The following is a description of a gene set: species: Homo sapiens Human Gene Set: GOBP_REGULATION_OF_PEPTIDASE_ACTIVITY Any process that modulates the frequency, rate or extent of peptidase activity, the hydrolysis of peptide bonds within proteins., and this is the list of marker genes: SERPINB9, PSENEN, CR1, CRB2, FETUB, PRSS22, SEMG2, SEMG1, ATP13A2, SERPINB1, EPPIN (NCBI Gene Id 57155), RCN3, TIMP2, TANK, TIMP1, SPOCK3, GAPDH, SVBP (small vasohibin binding protein, NCBI Gene Id 374969), PRELID1, MBP, UBXN1, SERPINB13, ECM1 (NCBI Gene Id 1893), SERPINB8, RECK, VSIR, VCP, SERPINB3, SPOCK2, GRN, A2ML1, SERPINB4